Given this list of marker genes Rbp7, Rbp1, Rlbp1, Crabp1, Abca4, Aldh1a2, Opn4, Akr1b8, Opn5, Rho, Crabp2, Opn3, Rbp2, Rbp3, Cyp2w1, Rbp4, Adh4, Stra6, here is a description of the gene set: species: Mus musculus Mouse Gene Set: GOMF_RETINAL_BINDING Binding to retinal, one of the forms of vitamin A. Retinal plays an important role in the visual process in most vertebrates, combining with opsins to form visual pigments in the retina.